Given this list of marker genes AKT1, AKT2, NCK2 (NCK adaptor protein 2), HSPA5, PTPN1, NCK1, ABCA7, ATAD3A, PPP1R15A, AKT3, DDRGK1, PPP1R15B, here is a description of the gene set: Human Gene Set: GOBP_NEGATIVE_REGULATION_OF_PERK_MEDIATED_UNFOLDED_PROTEIN_RESPONSE Any process that stops, prevents or reduces the frequency, rate or extent of the PERK-mediated unfolded protein response. species: Homo sapiens